Given this list of marker genes ITGB7 (integrin subunit beta 7), NEB, ACP7, FIS1, EDARADD, GPR25, TRIM46, AIFM3, ZDHHC15, TSPAN3, PURG, SLC2A9, GIMAP4, TLR2, AGPAT2, DPP4, MPST, RPL13A, LINC02291, SMIM30, PTPN18, B3GNT8, GPX4, S1PR4, IGKC, TMEM258, SLC13A1, EMP3, PDE4B (phosphodiesterase 4B), CATSPER2, TMEM71, APBB1, RABAC1 (NCBI Gene Id 10567), BMP5, DUSP28, ANP32A, CALCR, NUDT17, CRYZL1, UBE2F, PAXX, UPP1, HEXB, PPFIBP2, SERPINB1, C12orf56, TPD52L1, GPR63, SETD4, CFAP97D1, TCN2, MTIF3, MINAR2, CNBP, FBF1, RHOU, GPR108, C11orf71, RND3, KCNMB2, MTAP, CREB3, RPL18A, MACIR, NR3C2, BMP1, TMEM270, LHX3, HYI, PRCD, TSHR, IFFO2, WDR31, AP2A1, ITPK1, MUC16, DCLK2, ELOVL5 (NCBI Gene Id 60481), SCAND1, C3orf62, PRPF40B, PPP1R3C, TIFA, PCBD2, GULP1, LY86, RPS6KA5, HCAR1, MCF2, SLC5A11, AQP4, DGAT1, ACSF2, VKORC1, NGF, FAM43A, ADAT1, SLC16A7, CETN1, SLC17A7, SDHAF1, H3C7, YAP1, BCL2, ING1 (NCBI Gene Id 3621), ZDHHC11 (NCBI Gene Id 79844), HYAL2, TSC22D3, MOSPD3, UMOD, FNDC10, PHETA1 (NCBI Gene Id 144717), ABHD12, CFAP70, IFT140, RGMA, NGEF, LEMD1, ESYT1, TRIM34, SPMIP10, CSTB, HCST, CSNK1G2, FOXI1, SAMD5, HENMT1, GFOD1, LAMB3, CLBA1, BRME1, DCUN1D1, PIGP, CYBA, ALKBH7, CLPP, NEU2, SCAMP5, HES1, CCR5, FLACC1, DHTKD1, RPL39, CCDC150, ECI1, CACNA1C, CXCL12, YIF1A, LRRC66, HGD, MMP13, SBK1, CHAD, CDKN2D, HS3ST6, STYK1, HRH2, GP5, EPS8L3, CBX8, CSF2RB, PDIA2, TNFAIP2, DNAAF4, FAM32A, IMP3, RTP4, LDLRAP1, STOML3, ACTN3, MAEL, RIT1, RPS27, RNASET2, S100A10, FBXO27, FBN2, XKR8, PRR22, EPN3, CNTN6, H2AC25, AKT3, RHEBL1, PIRT, KRTAP8-1, USB1, DAPL1, NCF4, TNFAIP8L2, STS, CARMIL1, ORM2, MAP4K3, PRAMEF25, TMEM255A, HSD17B11, WBP2NL, NSMCE4A, AAMDC, here is a description of the gene set: Type I and type II interferons (IFNs) bind to different cell surface receptors but activate overlapping signal transduction pathways. We examined the effects of a type I IFN (IFN-acon1) and a type II iFN (IFN-g1b) on gene experession in A549 cells and demonstrate that there is a common set of genes modulated by both IFNs as well as a set of gene specifically regulated by each, reflecting the activation of different signaling pathways. In particualr, IFN-g induced many more genes of the signaling pathways, apoptosis, and cytokine interactions than did IFN-a. Even with genes induced by both IFNs there were distinctive quantitativive differences in expression. IFN-g1b plays a major role in the induction and regulation of the complement pathway. Previous work has shown a synergistic antivral and antiproliferative effect of type I and type II IFNs in cell culture and in the treament of tumors in mice. We demonstrate that a majority of genes showed and additive effect of IFN-acon1 and IFN-g1b, but a subset of gene is synergistically induced; these incluce ISG10, MX2, OAS2, and other genes known to be involved in the antiviral response, TRAIL (TNFSF10) and caspases involved in apoptosis and chemokine genes RANTES, CXCL10, and CXCL11. Greater than additive transcription of some of these genes in the presence of both IFNs was confirmed by real-time kinetic RT-PCR. Elevated induction of many of these genes may be sufficient to explain the synergistic antiviral and antitumor effects of this combination of IFNS in vivo. from publication Sanda C, Weitzel P, Tsukahara T, Schaley J, Edenberg HJ, Stephens MA, McClintick JN, Blatt LM, Li L, Brodsky L, Taylor MW (PMID 16800785) studied in species Homo sapiens Human Gene Set: GSE5542_IFNG_VS_IFNA_TREATED_EPITHELIAL_CELLS_6H_DN Genes down-regulated in epithelial cells (6h): IFNG versus interferon alpha.